The following is a description of a gene set: Mouse Gene Set: GOCC_ORGANELLAR_RIBOSOME species: Mus musculus A ribosome contained within a subcellular membrane-bounded organelle., and this is the list of marker genes: Mrpl20, Mrps6, Mrpl28, Mrpl34, Mrpl37, Mrps28, Mrps30, Mrpl9, Mrpl47, Mterf4, Mrpl4, Chchd1, Mrpl55, Mrpl17, Mrps7, Mrpl33, Mrpl24, Mtg2 (mitochondrial ribosome associated GTPase 2), Mtg1, Mrpl42, Mrps18a, Mrpl16, Mrps26, Mrps12, Mrpl43, Mrpl48, Mrpl21, mt-Rnr1, Mrps9, Mrpl12, Mrpl35, Mrpl49, Nsun3, Mrps18c, Mrpl40, Mrpl52, Mrps11, Mrps14, Mrpl54, Mrpl13, Mrpl46, Aurkaip1, Mrpl27, Mrpl19 (mitochondrial ribosomal protein L19), Mrpl22, Mrps27, Mrpl30, Mrpl44, Mrps25, Mrps22, Nsun4, Mrpl53, Mpv17l2, Mrps31 (NCBI Gene Id 80402), Mrps17, Mrps5, Mrpl51, Mrpl15, Dap3, Mrpl50, Mrpl58, Mrpl18, Gadd45gip1, Mrpl2, Mrps24, Mrps18b (mitochondrial ribosomal protein S18B), Mrpl23, Mrps2, Mrpl36, Mrpl45, Mrps33, Mrpl11, Mrpl39, Mrps34, Mrps23, Mrps10, Mrpl41, Mrpl57, Mrpl1, Mrpl38, Ptcd3, Mrpl3, mt-Rnr2, Mrps21, Mrpl14, Mrpl32, Mrpl10, Mrps16, Mrps35, Mrps15